The following is a description of a gene set: Human Gene Set: GOMF_RECEPTOR_SERINE_THREONINE_KINASE_BINDING species: Homo sapiens Binding to a receptor that possesses protein serine/threonine kinase activity., and this is the list of marker genes: PYCARD, OPRD1, FKBP1A, MAGI2, SCUBE3, GPR17, BMP4, RSPO2, CFC1 (NCBI Gene Id 55997), INHBA, FADD, SMAD7, NEO1, CRIPTO3 (cripto, EGF-CFC family member 3), CFC1B, BMP5, BMP2, SRC, SMAD6, SMURF1, MDM2, NODAL, CRIPTO, BMP7, OPRK1, BMP3, CDH5, BMP6, ELAPOR2, BMP10